The following is a description of a gene set: Cancer cells differentiate along specific lineages that largely determine their clinical and biologic behavior. Distinct cancer phenotypes from different cells and organs likely result from unique gene expression repertoires established in the embryo and maintained after malignant transformation. We used comprehensive gene expression analysis to examine this concept in the prostate, an organ with a tractable developmental program and a high propensity for cancer. We focused on gene expression in the murine prostate rudiment at three time points during the first 48 h of exposure to androgen, which initiates proliferation and invasion of prostate epithelial buds into surrounding urogenital sinus mesenchyme. Here, we show that androgen exposure regulates genes previously implicated in prostate carcinogenesis comprising pathways for the phosphatase and tensin homolog (PTEN), fibroblast growth factor (FGF)/mitogen-activated protein kinase (MAPK), and Wnt signaling along with cellular programs regulating such 'hallmarks' of cancer as angiogenesis, apoptosis, migration and proliferation. We found statistically significant evidence for novel androgen-induced gene regulation events that establish and/or maintain prostate cell fate. These include modulation of gene expression through microRNAs, expression of specific transcription factors, and regulation of their predicted targets. By querying public gene expression databases from other tissues, we found that rather than generally characterizing androgen exposure or epithelial budding, the early prostate development program more closely resembles the program for human prostate cancer. Most importantly, early androgen-regulated genes and functional themes associated with prostate development were highly enriched in contrasts between increasingly lethal forms of prostate cancer, confirming a 'reactivation' of embryonic pathways for proliferation and invasion in prostate cancer progression. Among the genes with the most significant links to the development and cancer, we highlight coordinate induction of the transcription factor Sox9 and suppression of the proapoptotic phospholipid-binding protein Annexin A1 that link early prostate development to early prostate carcinogenesis. These results credential early prostate development as a reliable and valid model system for the investigation of genes and pathways that drive prostate cancer. Early prostate development genes (up-regulated at 6 hr dihydrotestosterone) which are also up-regulated in localized vs metastatic prostate cancers. Human Gene Set: SCHAEFFER_PROSTATE_DEVELOPMENT_AND_CANCER_BOX4_UP studied in species Mus musculus from publication Schaeffer EM, Marchionni L, Huang Z, Simons B, Blackman A, Yu W, Parmigiani G, Berman DM (PMID 18794802), and this is the list of marker genes: NAV1, WAC (NCBI Gene Id 55468), KLHDC10, IRF2BP2, CAVIN2, FABP4, NCOA6, ZMYND8, KRT19, PRKCB, SIN3B